Given this list of marker genes CHMP2A, VPS4B, SMPD3 (NCBI Gene Id 79756), TSG101, VPS4A, SNF8, RAB7A (NCBI Gene Id 7879), STAM (NCBI Gene Id 8027), PDCD6IP, SDC1 (syndecan 1), SDCBP, HGS, SDC4, ATP13A2, IFNG, here is a description of the gene set: studied in species Homo sapiens Human Gene Set: GOBP_POSITIVE_REGULATION_OF_EXOSOMAL_SECRETION Any process that activates or increases the frequency, rate or extent of exosomal secretion.